The following is a description of a gene set: studied in species Homo sapiens Human Gene Set: HP_HEPATIC_VEIN_THROMBOSIS An obstruction in the veins of the liver caused by a blood clot (thrombosis). Hepatic vein thrombosis, and this is the list of marker genes: MPL, CD55, TP53, TET2, SERPINC1, CALR, JAK2, SH2B3, F5 (coagulation factor V), PIGM